Given this list of marker genes TK2, SYNJ1, MECP2, POLG, SLC18A2, ACBD6, ATP13A2, COL12A1, TMEM106B, WARS2, here is a description of the gene set: Stooped posture studied in species Homo sapiens A habitual positioning of the body with the head and upper back bent forward. Human Gene Set: HP_STOOPED_POSTURE